Given this list of marker genes Cyp26c1, Sp1, Srd5a3, Akr1c18, Cyp26a1, Strap, Cyp2w1, Cyp26b1, Bco2, Plpp6, Amacr, Klf9, Bco1, here is a description of the gene set: Mouse Gene Set: GOBP_ISOPRENOID_CATABOLIC_PROCESS The chemical reactions and pathways resulting in the breakdown of an isoprenoid compound, isoprene (2-methylbuta-1,3-diene) or compounds containing or derived from linked isoprene (3-methyl-2-butenylene) residues. studied in species Mus musculus